Given this list of marker genes F7, ABCB1, GCLC, GCLM, TOMM70, here is a description of the gene set: species: Homo sapiens A change in state or activity of a cell or an organism (in terms of movement, secretion, enzyme production, gene expression, etc.) as a result of a thyroxine stimulus. Human Gene Set: GOBP_RESPONSE_TO_THYROXINE